The following is a description of a gene set: studied in species Homo sapiens Any process that modulates the rate, frequency or extent of glomerulus development, the progression of the glomerulus over time from its initial formation until its mature state. The glomerulus is a capillary tuft surrounded by Bowman's capsule in nephrons of the vertebrate kidney. Human Gene Set: GOBP_REGULATION_OF_GLOMERULUS_DEVELOPMENT, and this is the list of marker genes: AGTR2, PPP3CA, NOG, RET, BMP4, PAX2